The following is a description of a gene set: Cytokines mediate cell-cell communication in the immune system and represent important therapeutic targets. A myriad of studies have highlighted their central role in immune function, yet we lack a global view of the cellular responses of each immune cell type to each cytokine. To address this gap, the authors created the Immune Dictionary, a compendium of single-cell transcriptomic profiles of more than 17 immune cell types in response to each of 86 cytokines (>1,400 cytokine-cell type combinations) in mouse lymph nodes in vivo. A cytokine-centric view of the dictionary revealed that most cytokines induce highly cell-type-specific responses. For example, the inflammatory cytokine interleukin-1β induces distinct gene programmes in almost every cell type. A cell-type-centric view of the dictionary identified more than 66 cytokine-driven cellular polarization states across immune cell types, including previously uncharacterized states such as an interleukin-18-induced polyfunctional natural killer cell state. studied in species Mus musculus Mouse Gene Set: CUI_ILC_IFNA1_RESPONSE_UP Genes positively differentially expressed in cell type: ILC (innate lymphoid cell) upon treatment with cytokine: IFN-α1 in mouse lymph nodes in vivo. from publication Cui A, Huang T, Li S, Ma A, Pérez JL, Sander C, Keskin DB, Wu CJ, Fraenkel E, Hacohen N (PMID 38057668), and this is the list of marker genes: Daxx, Ifitm3, Ifit1, Slfn5, Mrpl18, Tnfsf10, Iigp1, Oasl2 (2'-5' oligoadenylate synthetase-like 2), Epsti1, H2-T23, Ifih1, Ifi209, Phf11c, Ifit3, Zbp1, Oas3, Cxcl10, Isg15, Phf11b, Rtp4, Pml, Ifi47, Ms4a4b, Bst2, Irf7, Gbp9, Gbp6, Xaf1, Trim30d, Ms4a4c, Herc6, Ifi206, Psmb10, Trim30a, Rnf213, Isg20